The following is a description of a gene set: Human Gene Set: GSE11961_PLASMA_CELL_DAY7_VS_MEMORY_BCELL_DAY40_UP from publication Kaji T, Ishige A, Hikida M, Taka J, Hijikata A, Kubo M, Nagashima T, Takahashi Y, Kurosaki T, Okada M, Ohara O, Rajewsky K, Takemori T (PMID 23027924) To obtain insight into the genetic basis of the increase of functional activity of memory B cells over time, we compared the gene expression profiles of day 7 and day 40 NP-specific/IgG1 memory B cells, GC B cells and plasma cells in immunized WT mice and naïve B cells, before and after activation in vitro. species: Homo sapiens Genes up-regulated in day 7 plasma cells versus day 40 memory B cells., and this is the list of marker genes: TPST1, FGF2, GAS7 (growth arrest specific 7), UBE2E1, SMNDC1, LIMS4, FAM117A, CD72, MMUT, ZFX, CMTM3, MAOA, RPL3, ADORA2A, POU2F2, GLE1, CSTF2, DOK2, INCA1 (NCBI Gene Id 388324), WDR77, AKAP8, HNRNPK, PCNP, IMPA1, EYA1, DTNA, MDH1, NDUFA12, EIF3K, RAB3IL1, FSCN1, LY9, POLR1B, RBL1, C11orf58, ZC2HC1C, RAB17, HAUS5, FNTA, KLRD1, RAB5A, EIF2A, SLC35A2, PLK4, ZDHHC9 (NCBI Gene Id 93950), ZFP14, EPB41L4A, ADAMDEC1, MYF5, RBBP7, TSPAN13, RPS4X, SRSF10, PSMD12, FNBP4, UBA2, GJC1, ITPK1, EVL, PAK4, GTF2F1 (general transcription factor IIF subunit 1), SIM2, CD53, HESX1, RND2, EBF2, CIP2A, MTTP, TOP2B, EBNA1BP2, VTI1B, VDAC2, CITED2, CASQ2, KCNB1, SMS, WWC1 (WW and C2 domain containing 1), OPRD1, PARL, UGT8, HTR1D, ANKFY1, H1-4, RABEP1, MYB, CD9, GNG10 (NCBI Gene Id 2790), MARCHF7 (NCBI Gene Id 64844), MYADM, MUC13, PNRC1, RIOX2, SSTR5, PDK1, TACR2, OSER1, TMX1, ACTG1, GPRASP1, KRT86, ANPEP, LGALS3, ANXA4, SDCBP, ITIH5, ANXA1, RPL24, SH3BGRL, MRPL24 (mitochondrial ribosomal protein L24), EXOSC7, SSTR4 (NCBI Gene Id 6754), CDK18 (NCBI Gene Id 5129), CYRIB, GOLPH3, SYTL4, WFS1, KIF16B, HLA-E, DCN (NCBI Gene Id 1634), GLRB, CA1, GABPA, IGFBP6 (insulin like growth factor binding protein 6), RAB3A, CD28, ATP6V1B2, CREG1, G3BP1, CCR1, MYRF, SMARCD1, SMYD2, ATAD2B, H1-3, MRTO4, ISLR, CREBRF, MAX, NUDCD3, GATA2, IFT25, YWHAB, IPO7 (importin 7), NINJ1, ITGB3, PTPN23, MGLL, STT3B (STT3 oligosaccharyltransferase complex catalytic subunit B), PTPRG, MOGAT2, GPN1, PDPK1, STMN1, HAS1, CCRL2 (C-C motif chemokine receptor like 2), PEPD, IFT70B, SLC23A3, POLE3, CYP4A11, SLC25A20, CD82 (NCBI Gene Id 8052), RALGDS, MMP12, GSTM5, UBE2T, UPP1, MYO6, PRIM1, IGSF10, ATP6V1C1, KIF20A, LTK, CD83, PDE4DIP, GBP7, MINDY1, COL12A1, SRCIN1, CDKN1C, GNAI2, EIF1, SEMA6A, GABRB3, HNRNPA3, CRMP1, OAZ2, PSIP1, PTGDR, CYTIP, MUTYH, UBE2N, ALAD, PHF23, KLHL9, JPT1, THBD, MT4, KCNJ5, POLR3A